Given this list of marker genes C1QTNF8, ANKRD19P, LINC02600, ARIH2 (NCBI Gene Id 10425), POLR2F, PRKD2, GPR137, LINC01012, STPG3 (sperm-tail PG-rich repeat containing 3), CKM, P2RY1, ADAMTSL5, CD81, PPARGC1B, TEFM, HGFAC, HIPK1, SF3A2, PBLD, ENSG00000238410, YIF1B, HAGHL, RASAL1, WDR36, LONP1, SSUH2, NDUFB10, SLC25A20, SLC23A1, MVB12A, PDXK, OVOL2, BRCA2, DENND3 (NCBI Gene Id 22898), TMEM200B, GALNT6, LRRC25, TRAK1, TNFRSF14-AS1, MMP2, SPOCD1, RNU5A-1, LRP8-DT, UQCR11, TRPV1, CERS4, PRR22, COG5, BBIP1, GCNT3, HBS1L, FIBCD1, TMEM273, MIR1249, SAXO5, MDGA1, EEPD1, FBLN2, HDAC1, CATSPERG, ENSG00000262999, SPSB1, DACT3-AS1, TMEM44, SMAD3, DOK4, CENPU, BCAR3, TGFBR3L, TSC2 (NCBI Gene Id 7249), SH2D3A, TSPAN31, FBXL19, DNAH2, RHOF, ZSCAN25, VARS2, MAST3, MYO18B, KRT14, SIRT6, LINC00051, PLIN4, FBN3, AMBP, ACTMAP, PRSS27, LINC03046, NAPG, SH2D5, CCDC78, ERCC1, SPTBN4, SMARCC2, ENSG00000279801, ALPL, SIN3A, KRTDAP, CCDC33-AS1, MIR379, ASPHD2, SEPTIN9, NEK7, MIR6745, ZNF746, HBA1, TTC41P, SLC38A10, AKT2, GHRHR, BMP7, PLEKHA7, TILAM, TEDC1, CUX1, CES5A, RFXANK, RPA2, CCDC71, RHBDL1, MYO7A, MIR4311, PIM3, IGFBP6, PELI3, OLFM1, PPP2R2C, HID1, HSPA12A, PLCD3, TOGARAM2, BTG2, IER5L-AS1, ZSWIM3, PLXND1, NPR3, SPDEF, SLC8A2, ARL2BPP10, PLD3, PC, TRAPPC9, ADCY7, KISS1, ZNF573, HLA-DPB1, TWF1P1, NICOL1 (NELL2 interacting cell ontogeny regulator 1), TMOD3, IL9RP6, NEURL1, ELK3, RBX1, BEAN1, CIC, GRAP2, FBXW2, ODF2-AS1 (NCBI Gene Id 107080620), FBXO2, ABCG4, KRT42P (NCBI Gene Id 730844), MAN1C1, KLF11, UBXN6, PAK4, GAMT, ECE1, SMUG1P1, ACTRT2, DACT3, GTPBP3, BTG2-DT, STH, GMFG, CSTF1, NUDT14, BHLHE22-AS1, RNU6-1241P, STK10, LZTS3, NOSIP, TMEM125, PGLS, CSRNP1, HPS3, PLOD2 (NCBI Gene Id 5352), SYNGR3, SFTPC, BTBD2, ATP8B4, LINC02560, ING1, SHOC2 (NCBI Gene Id 8036), FUT1, TPM4, DENND3-AS1, ZNF514, KCNQ2, MT-ND4, CTSD, DUSP10, IFITM9P, SARS2, TBX21, TRIM62, ATIC, ECHDC2, SLC2A1, ENSG00000283573, FAM83G, RNU6ATAC18P, PKMYT1, PIANP, LINC01503, MEG9, SMASR, GCC2, CACTIN, PACSIN1, MTHFSD, STAB2, FERMT3, ACOX3, ATP2C2, FADS1, LINC02298 (long intergenic non-protein coding RNA 2298), SCFD1, NR5A1 (nuclear receptor subfamily 5 group A member 1), SCAMP4, IFI27, TRAF2, REEP6, VSIG10L, MAP3K11, BEAN1-AS1, SMYD4, GGA1, PRMT1, TOB1-AS1, PNLIPRP1, HEXA-AS1, GRB7, SUPT5H, HOTAIRM1, C1QTNF1, SLC4A11, EML1, YIPF6, ABCA7, ATOSA, SREBF1, TTC39A, RPL7AP12, LRRC45, ARHGAP45 (Rho GTPase activating protein 45), ESAM, TEX38, CCDC12, KLC3, KIAA0930, TMEM259, HNRNPU, MIR6753, DPP7, SLC30A3, TMEM59L, STPG3-AS1, SEMA4F, ZNF226, ARHGEF19, CCDC117, OACYLP, AURKA, TMC8, PRKCSH, ADAP2, ALOX5, MDFI, CXXC5, ZFYVE28, ALK, CIT, GTF2H4, ITIH1, NELFA (negative elongation factor complex member A), KCNH3, PROSER2 (NCBI Gene Id 254427), HSPB7, SPATA20, OSM (oncostatin M), NUCB1, RNASEL, PALM, NR4A1, SEMA4A, LCTL, NBEAL2, TNFRSF18, TREHP1, ADGRG1, LINC02255, SEPTIN2, PEPD, THBS3, RNU7-124P, AIFM3, RHBDF1, LRRC34, PDGFRB, DVL3, ANPEP, FKBP8, RHOBTB2, ETV4, ENSG00000237429, KLK8, DEPDC4, CNGB1 (cyclic nucleotide gated channel subunit beta 1), CAMKK1, MIR4425, DOCK7-DT, MTX1, RAC1, NEK6, CTIF, SNX29, BEGAIN, MELTF (melanotransferrin), ARHGEF16, HJV, PTPRS, GORASP1, TMEM132A, SPAG1, MFNG, KRTAP13-4, ANKRD18A, GFER, MDS2, FSCN1, MED7, LINC01234, EMID1, NPVF, ATG4D, CD7, PIK3R2, LINC00620, TIMM44, ESPN, EPS8L1, VIPR1, PACSIN3, MAPK11, DPF1, RDH13, LAD1 (NCBI Gene Id 3898), RPA1, RNU6-560P, POLM, NCF4, CERKL, MCFD2, NELFB, DDX11, CMTM8, PLA2G6, ADAT3, ITK, TSPEAR-AS1, CELA3B, KLHL17, ENSG00000253295, NDRG1, ABHD6, LST1, IQCE (NCBI Gene Id 54774), RNU2-19P, MICAL2, NMRK2, LINC00906, TAOK1, LINC01548 (NCBI Gene Id 728409), CDIPT, LIPE-AS1, GABBR2, GBX2 (NCBI Gene Id 2637), TMC6, PIDD1, PLEKHA6, SRC, ENSG00000232876 (novel transcript), NKPD1, UNC119, ANKRD18B (NCBI Gene Id 441459), HSD11B1L, FCHO1, SPINT2 (serine peptidase inhibitor, Kunitz type 2), MTND5P11, KISS1R, TAF4B, PRR5, UNC13A, RGS14, MAP3K10, SLC44A4, SHKBP1 (SH3KBP1 binding protein 1), VGLL4, RAI1, NES, ECH1, AKNA, HEXA, EYA2, RPL5, PFKL, TMPRSS9, KRT17P4, RASL12, STARD10, BCAS4, MRI1 (NCBI Gene Id 84245), S100A9, PITPNA, AP2S1, CIZ1, CSK, EPN3, SH2B3, FBXO17, NIPAL4, MYO15B, EEFSEC, TFCP2L1, CYP4F22, LDLRAP1, C2orf72, MIR3619, PRR14, FOXN4, ENSG00000260136 (novel transcript), ABTB1, IDH3G, SLC11A2, TCF3, SYNGR2, MAP1S, ZMAT2, B4GALT1-AS1, CROCC, ARHGAP4, LOXL1, GLIPR2, LINC02517, RHCE, SSPOP, PRUNE1, ACOT8 (NCBI Gene Id 10005), CCDC42, LINC01472, SRPK2, MFGE8, LASP1, ZAR1L, NKAIN4, ANKRD18DP, FAM201A, LINC00963, CSF2RB, TPRA1 (transmembrane protein adipocyte associated 1), DRAM1, ZNRF3-AS1, MLXIPL, HIPK1-AS1, ANKS1B, CCDC136, PIH1D1, TRMT1, CDIPTOSP, SYTL1, MTCO3P12, DOCK7, LINC01838, TNFRSF13B, LRP8, ANKRD54, COL6A3, PCSK4, ZNF221, SGCA, ALDH3B1, CFAP73, ELOVL6, LINC00856, RIPOR1, POU6F1, SLC8B1, CRK, ITIH4-AS1, CTSW, SMCO4, ULK3, ATP6V0E2, PTK6, PABIR1, SAMD11, APRT, FGF21, RN7SL665P, TRPV3, PSMF1, RBM42, KXD1, RASL10A, ATPAF1, here is a description of the gene set: Genes containing one or more binding sites for (ZNF436) in their promoter regions (TSS -1000,+100 bp) as identified by GTRD version 20.06 ChIP-seq harmonization. from publication Yevshin I, Sharipov R, Kolmykov S, Kondrakhin Y, Kolpakov F (PMID 30445619) Human Gene Set: ZNF436_TARGET_GENES studied in species Homo sapiens